Given this list of marker genes PGRMC2, ELL, SEC11A, FAM81A, PLEKHF2 (NCBI Gene Id 79666), BCAT1, GAN, USF3, NSD2, SNTB1, ARL8B, SHC1, ARFIP1, GNA13, SLC9A2, MTUS2, TRIM39, SLC25A53, SPTBN1, RYR3, LRRC1, USP38, HCN1, ZKSCAN8, MAVS, SCAF11, BCL7A, STT3A, SRGAP1, ZKSCAN4, ABRA, SOS2, PTBP1, PDE12, KAT7, ADAMTS5, PCDH9 (NCBI Gene Id 57123), MESD (mesoderm development LRP chaperone), NCOA4, MTM1, PAQR3, ZMPSTE24, ELK3, SSMEM1, SNTB2, FRMD4B, JADE3, ENY2, KAT2B, GMFB, YWHAZ, WTAP, TIMM8A, YME1L1, RHOB, CXADR, TPST2, TMEM33, USP14, HOXD1, RTL4, GDF5, TAOK1, SCOC, NAT8L, GOLGA8T, NAPEPLD, NYNRIN, GLI3, SLC17A6, SLC35G1, SNX18, BACE2, MORN4, PICALM, CBL, RHBDF1, UNC5D, PDCD6, TCF3, CTNND1, SEC24D (NCBI Gene Id 9871), ZBTB33 (NCBI Gene Id 10009), S1PR3, GOLGA8N, CHST14 (NCBI Gene Id 89881), SLAIN1, PIK3C2A, DNAL1, TMEM47, HECTD2, CC2D1B, PLAG1, GRAMD1B, DGAT2, ARMC1, PDSS1, ZCCHC24, POLR3G, SCN3A, SUSD6, FAM177A1, ERGIC1, DGKK, GRID1 (glutamate ionotropic receptor delta type subunit 1), SLC25A37, SPPL2A, PLOD3, HADHB (NCBI Gene Id 3032), ELOVL5, TMEM128, MAPK14 (NCBI Gene Id 1432), LEMD3, SYT14, AQP3, GLRB, KIF24, VPS4B, MYRF, SLC38A2, ANKMY2, TWF1, MAP3K3, ATF7IP, SEMA6D, ARHGAP44, GCH1, PKN2, EAF1, NIPSNAP2, ABCD2, RHOG (NCBI Gene Id 391), OSBPL10, EIF3B, LIFR, GPR171, PRR14L, KCNK4, CDK19, SLC30A3, ENDOD1, KIAA2013, CEP85, RAPH1, TCEANC, CDV3, MTMR10, PROX1, ZNF436, ST3GAL1, RHBDL3, CENPU, NEK9, HTATIP2, NSUN2, GNAL, PTPRZ1, ITGB1, ZNF304, KIF21A, FMNL2, LPP, HDHD5, MAN2A1, GOLGB1, PTPN9, ZBTB41, BLOC1S5, KCNIP1, SFT2D2, ARHGEF37, PPM1E, CAPRIN2, LANCL1, GOLGA8R, RNPEPL1, LIMCH1, CYYR1, CHSY1, SGPL1, NEDD4L, TSC22D1, GOLGA8H (golgin A8 family member H), CHP1, SENP2, CPSF4, CREBRF, IRF2BPL, SLC8A1, PTBP3, DYRK2, IQGAP2, CYB5A, TMEM263, RNF135, TMEM41A, USP1, SOCS5 (suppressor of cytokine signaling 5), TFDP2, ZNF398, MROH1, ESR1, ONECUT2, SIX4, ATP2C1 (NCBI Gene Id 612), STEAP3, GGA2, PAQR9, TM9SF2, SPOPL, FMC1-LUC7L2, FBXW11, GDF9, ECI2, TRIM66, SGPP1, B4GALT5, CAP2, GOLGA8M, JADE1, MYZAP, ZDHHC2, SGK1, CALCOCO1, ABITRAM, HSD17B10, EYA4, ANTXR2 (NCBI Gene Id 118429), SLC31A2, RRAS, MIB1, TBX15, STON2, MAP3K2, PATL2, LAMC1, CREB3L2, DNAJB14, FZD5, GOLGA6C, XYLT1, TMCO3, ALDH1L2, LRRTM2, SLC35D1, CD84 (CD84 molecule), STK32A, CDCP1, NPAT, SYNJ2BP, ZNF449, SOX8, DMRTA1, SP1, U2SURP, STK26, GAB1, FNDC3B, CD2AP, CTNNA3, DIP2A, SEMA6A (semaphorin 6A), FUT8, FSTL5, NUFIP1, GDAP1L1, SLC16A1, GPATCH8, NPY1R, KDM3B, CNOT6L, GATAD2B, CAMKV, DDX3X, SERF2, MSR1, UHRF2, KPNA3, NID1, GIT2, MSRB3, PRC1, ANKHD1, SGSM1, ZSCAN22, CPD, RAB11FIP5, CTDSP2, ZNF131, TMEM87B, E2F3, GDAP2, TWSG1, GOLGA8J, FLRT3, TNRC6B, SCN2A, GPT2, KCTD9, ADRA2A, SLC7A14, CPA3, GSTCD, HIVEP2, VPS35, LUC7L2, CDH9, MON2, SLC31A1, RFX4, RFX3, POGLUT1, ZFAND5, EVI5, WASF2, G3BP1, MAP2K1, ATP1A1, ANKRD27, VAT1L, BPNT2, PCDH8, FLOT1, CTDSPL, B4GALT1, UBTD2 (ubiquitin domain containing 2), PLEKHG2, FSD1L, TMED1, ACADVL, PLXNC1, CMPK1, PPIF, TFEB, NEURL1B, ABCA9, CRIPTO, GALNT1, MINDY2, PPP1R2, TSHZ1, UXS1, ATRN, AMOTL1, P4HA1, FCHO2, NFIA, ANKRD50 (NCBI Gene Id 57182), FAM133B, CDK2, SUCO, PLCB1, GAREM1, GOLGA8B, SBNO2, UBE3A, PRKAA2, ATF7, RB1CC1, CLIC6, AMOT, KIF2A, CCDC177, UMAD1, HIVEP1, SKI, EIF4EBP1, WDR44, SHISAL1, CDCA7L, CCND2, CCDC141, ARHGAP29, RAB38, PARP16, TCF12, AKAP6 (NCBI Gene Id 9472), PTPMT1, RAP1A, SEPSECS, CCR3, NR4A2, C2orf69, PHF13, CLOCK, DNAJC1, JAKMIP2, MINAR1, TUB, PGM5, here is a description of the gene set: studied in species Homo sapiens Human Gene Set: MIR5582_5P Genes predicted to be targets of miRBase v22 microRNA hsa-miR-5582-5p in miRDB v6.0 with MirTarget v4 prediction scores > 80 (high confidence targets). from publication Chen Y, Wang X (PMID 31504780)